The following is a description of a gene set: DNA double-strand breaks are generated by genotoxic agents and by cellular endonucleases as intermediates of several important physiological processes. The cellular response to genotoxic DNA breaks includes the activation of transcriptional programs known primarily to regulate cell-cycle checkpoints and cell survival. DNA double-strand breaks are generated in all developing lymphocytes during the assembly of antigen receptor genes, a process that is essential for normal lymphocyte development. Here we show that in murine lymphocytes these physiological DNA breaks activate a broad transcriptional program. This program transcends the canonical DNA double-strand break response and includes many genes that regulate diverse cellular processes important for lymphocyte development. Moreover, the expression of several of these genes is regulated similarly in response to genotoxic DNA damage. Thus, physiological DNA double-strand breaks provide cues that can regulate cell-type-specific processes not directly involved in maintaining the integrity of the genome, and genotoxic DNA breaks could disrupt normal cellular functions by corrupting these processes. Human Gene Set: BREDEMEYER_RAG_SIGNALING_NOT_VIA_ATM_DN studied in species Mus musculus from publication Bredemeyer AL, Helmink BA, Innes CL, Calderon B, McGinnis LM, Mahowald GK, Gapud EJ, Walker LM, Collins JB, Weaver BK, Mandik-Nayak L, Schreiber RD, Allen PM, May MJ, Paules RS, Bassing CH, Sleckman BP (PMID 18849970) Genes down-regulated in pre B lymphocyte after induction of physiological DNA double-strand breaks (DSB) by RAG2; the changes are independent of ATM signaling., and this is the list of marker genes: CRLF1, RNF122, KANTR, ZNF780B, ABHD14A, CENPA, SLX1A, OSR2, PYURF, TF, RIOK3, GIMAP5, CCBE1, RPAP2, SMURF1, GPSM1, KBTBD2, LANCL1, IRGM, RFC3, SCN8A, TMEM100, SLC15A2, KREMEN1, RAB19, CACNA1H, IFT22, MSH5, LIFR, SLPI, ASPH, FUNDC2, CLEC2D, PCBP4, KLRD1, PI4K2A, PDZD2, ABCA1, HLA-DRA, HVCN1, RGS18, SNX10, IMP4, EIF2S1, JAKMIP1, AVL9, GFOD1, DUSP3, NAGLU, SLC11A2, TECPR1, NAV2, ZW10, RASGRP3, ASB10, SULT1A1, TSPAN2, HIPK2, ARVCF (ARVCF delta catenin family member)